The following is a description of a gene set: species: Mus musculus from publication Chen Y, Wang X (PMID 31504780) Mouse Gene Set: MIR_7216_3P Genes predicted to be targets of miRBase v22 microRNA mmu_miR_7216_3p in miRDB v6.0 with MirTarget v4 prediction scores > 80 (high confidence targets)., and this is the list of marker genes: Trim10 (NCBI Gene Id 19824), Ern1, Senp7, Rpl4, Stk3, Clcn4, Pcgf6, Epha5, Ell2, Map3k2, Arid1a, Rundc3b, Setd5, Xrn1, Nt5e, Chic1, Pla2g2d, Clip3, Jade3, Sp1, Zfp354a, Wtap, Sowahc, Serpinb7, Sptlc1, Sema3a, Serpinb9, Msl2 (MSL complex subunit 2), Mbtd1, Zfp54, Zpld1, Fgf9, Ewsr1, Col3a1, Bend5, Ndufaf4, Zfpm2, Rsf1, Txndc9, Dennd6a, Sez6l, Bcs1l, Mllt10, Rapgef4, 1810065E05Rik, Prpf18, Chil3, Scml2, Eaf1 (NCBI Gene Id 74427), Zfp438, Ahr, Gda, Stag2, Nbea, Sh3bgrl2, Sdc2 (syndecan 2), Zeb2, Abhd17c, Pex13, Erich3, Zeb1, Crebzf, Mtfr1, Nalcn, Pom121, Nsd3, Osgepl1, Macir, Mier3, Pabir1, Atp8b2, Mycs, Pycard, Adam10, Dcc, Gca, Ubtd2, Syncrip, Hoxb2, Ppp1r16b, Exoc2, Zfp148, Ppp3cb, Nrsn2 (neurensin 2), Dock10, Pnisr, Hdac9, Rsu1, Eef2k, Etnk1, Foxa1, Capn6, Cntd1, Pgk1, Steap2, Med17, Runx2, Derl2, Zfp760, Bicd2, Arhgef28, Klhl38, Qdpr, Hsd17b8, Ube2w, Patz1, Ankrd13c, Tm9sf3, Hhip, Magi1 (membrane associated guanylate kinase, WW and PDZ domain containing 1), Pabpc1, Lsm14a, Ephb1, Gria2, Prickle2, Fbxo4, Fbxl5, Smr2l (submaxillary gland androgen regulated protein 2 like), Ddx46, Nr2c2, Stam, Chmp1b, Mplkipl1, Ddx17, Pltp, Cdh12, Metap1, Thnsl1, Mfsd8, Chil4, Sh3kbp1, Mid2, Txnrd1, Stat5b, Ankrd28, Cdk20, Csn1s1, Ttc23, Ncam2, Abr, Hdx, Tet3, Galnt3, Slc38a2, Dll1, Gmfb, Btbd7, Ms4a6d, Ppp1r3d, Hoxc10, Cacna2d1, Kmt5b, Mpeg1, Disp2, Dynll1, Emx2, Fcsk, Prss30, Ercc6l2, Gm5934